The following is a description of a gene set: Mouse Gene Set: GOBP_REGULATION_OF_LIPID_STORAGE Any process that modulates the rate, frequency or extent of lipid storage. Lipid storage is the accumulation and maintenance in cells or tissues of lipids, compounds soluble in organic solvents but insoluble or sparingly soluble in aqueous solvents. Lipid reserves can be accumulated during early developmental stages for mobilization and utilization at later stages of development. species: Mus musculus, and this is the list of marker genes: Mup5, Fto, Itgb3 (NCBI Gene Id 268495), Plin3, Apob, Trem2, Scarb1, Ces1e, Osbpl11, Mup4, Nfkb1, Ttc39b, Plin5, Alkbh7, Pparg, Cpt1a, Ces1f, Cd36, Mup3, Plin2, Zc3h12a, Abhd5, Tmem135, Ptpn2, Pnpla2, Lpl, Acacb, Mest, Crp, Ppard, Lep, Mup11, Asxl1, Ttc39d, Nfkbia, Mup1, Sirt1, Vstm2a, Hilpda, C3, Ces1d (NCBI Gene Id 104158), Ppara, Msr1, Ehd1, Ces1b, Pla2g10, Ikbke, Clstn3, Srebf2, Mup2, Nr1h2, Apoc4, Ces1c, Srebf1, Ces1h, Osbpl8, Nr1h3, Asxl2, Itgav, Abcg1, Fxn, Ces1a, Ces1g